The following is a description of a gene set: Any process that increases the rate, frequency, or extent of a response to cytokine stimulus. Human Gene Set: GOBP_POSITIVE_REGULATION_OF_RESPONSE_TO_CYTOKINE_STIMULUS studied in species Homo sapiens, and this is the list of marker genes: CASP4, IRF7, TAF9, CD74, TBK1, TRIM44, RNF185, CASP1, MMP8, CD40, TRAF2, DHX9, RBM47, AGPAT2, UBE2K, TLR4, GAS6, PARP14, STING1, PAFAH1B1, HSPA1A, NRDC, IFIH1, USP27X, AXL, MMP12 (matrix metallopeptidase 12), RIPK2, LSM14A, CDK5R1, TRIM41, NLRP6, MAVS, TRIM56, IRGM, USP29, CD300LF, EDN1, TICAM2, GFI1, NLRC5, WNT5A, CPNE1, RIGI, TRIM6, HIF1A, FADD, CREBRF, IL7, IKBKE, ADAM10, MIR1246, RIPK1, TRIM32, AGPAT1, HSPA1B, PRKN, LRRC70, PARP9 (poly(ADP-ribose) polymerase family member 9), CSF1, IRF3, CXCR4, IL1R1, ZBP1, C1QTNF4, MED1, TLR2, TSLP, LAPTM5, TXK, TREM2, ADAM17, HPX